Given this list of marker genes Ndufs5, Pik3ca, Fabp6, Bst1, Acads, Psmb2, Cyp7a1, Kera, B3gat2 (beta-1,3-glucuronyltransferase 2), Azin1, Gsta1, Hs3st3b1, Fabp2, Cyp24a1, Cds1, Fut2, Pip4k2c, Hgd, Pfkfb1, Pfas, Ttr, Ak7, Ddhd1, Mthfs, Fahd1, Pnpla6 (NCBI Gene Id 50767), Pla2g4b, Gnb5, Ndufa10, Cox7c, Kynu, Pnpla2 (NCBI Gene Id 68551), Me2, Inpp5k, Abhd4 (abhydrolase domain containing 4), Coq9, Slc5a5, Grhpr, Cox11, Nudt16, Isca1, Akr1c20, Cyp2a12, Hmox1, Slc25a18, Cd44, Hacd2, Phka2, Mtmr3, Enpp7, Mmab, Mkln1, Hal, Timm21, Mtmr14, Mrps36, Cyp2w1, Pgls, Lpin3, B3galnt1, Far2, Dcakd, Aaas, Aoc1, Fabp3, Glyat (glycine-N-acyltransferase), Pten, Hsd17b10, Fmo3, Gpc4, Aco1, Gatm, Miga2, Coq4, Gclm, Suclg2, Lyrm4, Sphk2, Abhd10, Osbpl2, Dpyd, Slc51a, Ugt2a3, Naxd (NAD(P)HX dehydratase), Gpi1, Ppara, Srd5a3, Lrp10, Mfsd2b, Slc44a3, Pik3r3, Pnlip, Cyp3a44, Ckm, Inpp5d, Rida, Gpat2, Mapkapk2, Th, Cyp2s1, Mocs1, Tstd1, Ptpn13, Slc25a51, Pip5k1b, Abcc1, Oca2, Gstm5, Ckmt2, Pgm2l1, Cpt1a, Sucla2, Ugt1a6a, Atp5mc2, Bpgm, Cyp3a59, Pitpnm3, Atp5me, Lpgat1, Rufy1, Alas2, Ndufb2, B4galt7, Cycs, Eci2, Cox10, Slc6a12, Ugt2b35, Nme3, Hkdc1, Rbp4, Hexa, Dbh, Gchfr, Crot, Cth, Pck1, L2hgdh, B4galnt2, Car12, Gba2, Aldh1l2, Agmo, Mmaa, Psmc1, Slc25a17, Gm2a, Smim20, Nup107, Entpd2, Tpi1, Ormdl2, Ak9, Hccs, Synj1, Ndufa13, Osbp, Pycr2, Ggt1, Bhmt, Cyp3a13 (cytochrome P450, family 3, subfamily a, polypeptide 13), Tat, Aox1, Phkg1, Abcc5, Csnk2b, Gmpr2, Lrp2, Podxl2, Nadsyn1, Pik3c3, Serinc4, Pla2g6, Cyp2e1, Mthfd1l, Pgam1, B3gnt2, Slc37a4, Ggt6, Psma7, Ndufc1, Dlst, Phykpl, Hs6st3, Akr1c21 (NCBI Gene Id 77337), Cmpk1 (cytidine/uridine monophosphate kinase 1), Ddah1, Nat2, Cox4i1, Pcbd1, Cyp3a25, Bphl, Gnb2, Tbxas1, Gna15, Ahcy, Sptlc2, Sumf2, Uck2, Pla2g5, Slc25a32, Calm3, Gng5, Ubb, Chst12, Csnk2a2, Pitpnm1, Fmod, G6pdx, Ust, Idh3a, Slco1a4, Nup160, Fabp1, Rab4a, Inpp5j, Pik3r6, Pla2g2d, Sgms2, Nmrk1, Ppa2, Fut1, Il4i1, Nudt19, Pank4, Plch2, Akr1c6, Pik3c2g, Acox1, Lipi, Slc25a14, Gng7, Slc5a8, Mccc2, Nsdhl, Far1, Rrm1, Lyrm2, Idua, Ndufaf8, Srebf2, Smox, Cyp4f39, Galk1, B3galt6, Lta4h, Got1, Arsj, Tk2, Ndufc2, Stard7, Cacna1a, Pdp2, Nme2, Agmat, Sdc4, Selenoi, Rapgef3, Isca2, Bco2, Neu2, Chst9, Dmac2l, Gpd1, Psat1, Bckdk, Psmd7, Eno2, Sumf1, Gart, Oxct2a, Gldc, B4galt2, Fmo2, Adrm1, Tbl1xr1, Pgam5, Adra2a, Akr1d1, Gpat4, Acot8 (NCBI Gene Id 170789), B4galt5, Elovl6, Itpr2, Cyp4f40, Akr1b8, Mvd, Xylb, Kcns3, Entpd6, Glb1, Cygb, Dmac2, Cyp39a1, Mgll, Aldh1l1, Acsl5 (acyl-CoA synthetase long-chain family member 5), Sumo2, Pik3c2b, Fbp2, Gm10053, Nt5e, Atp5f1b, Slco2b1, Ndufa11, Fdps, Gstz1, Stard10, Osbpl7, Adcy5, Cacnb2, Plcd4, Dcn, Cspg5 (chondroitin sulfate proteoglycan 5), Lypla1, Acsl4, Entpd4b, Surf1, Acbd4 (NCBI Gene Id 70268), Cyp2c66 (cytochrome P450, family 2, subfamily c, polypeptide 66), Psmb5, Umps, Hsd3b5, Acsm1, Psma5, Hsp90ab1, Abhd14b, Ffar1, Gpc5, Sgpp2, Ndufa12, Sult2a1, Alox12b, Comt, Cyp4a31, Slc25a13, Eci1 (enoyl-Coenzyme A delta isomerase 1), Cyp2c29 (NCBI Gene Id 13095), Acsl6, Acp5, Agxt, Ctps1, Akr1a1, Ggps1, Ugt1a1, Dguok, Arf1, Psph, Nup188, Acsm2, Vac14 (NCBI Gene Id 28016), Ormdl3, Aldob, Cda, Gid8, Ldha, Ahcyl, Apoa2, Itpa, Etnppl, Lpl, Trmt112, Pik3cb, Psma4, Acsm4, Cyp4f15, Aldoa, Lyve1, Txnrd1, B3gnt3, Inpp5b, Tymp, Hk2, Gstm6 (glutathione S-transferase, mu 6), Has3, St3gal3, Psmd14, Apom, Adal, Esd, Nudt18, Hao1, Gpx1, Gng11, Gpc3, Aspa, Has1, Gstp2, Idh3g, Ndufaf3, Cox6b1, Tk1, Gnb4, Plpp2, Ttpa, Cyb5b, Mbtps1, Psmc6, Fads2, Aanat, Scp2, Ranbp9, Alox5ap, Star, Sdhb, Adcy6, Cyp4f14, Fads1, Cryl1, Cyp3a57, Ppip5k1, Acot9, Csgalnact1, Ephx2, Has2, Hpdl, Smarcd3, Hlcs, Cyp17a1, Pom121, Cidec, Acot11, Cyp4a14, Atp5mk, Acat1, Ptdss2, Mthfr, Cyp2b23, Ncoa1, Entpd3, Nr1h4, Hpgd, B4galt4, Slc25a4, Pygl, Itpka, Amdhd1 (NCBI Gene Id 71761), Cemip, St3gal2, Slc35b3, Dnph1, Acsbg2, Sgpl1, Coq2, Fig4, Tmem186 (transmembrane protein 186), Tyms, Acat2, Nqo1, Oplah, Adipor2, Carm1 (coactivator-associated arginine methyltransferase 1), Mthfsl, Pla2r1, Gpc6, Nup37, Psmc5, Ppox, Pdxk, Tyr, Acadvl, Slc27a5, Cox4i2, Nudt12, Aoc3, Acp6, Cox8c, Ugt2b37, Hadhb, Ltc4s, Psma3, Coq10b, Cox6a1, Slc23a2, Gk2, Tpr, St6galnac6, Cyp2u1, Btd, Coq6, Mgst2, Atp5pf (ATP synthase peripheral stalk subunit F6), Tpst2, Gapdh (NCBI Gene Id 407972), Miox (myo-inositol oxygenase), Ehhadh, Papss1, Arsk, Gphn, Plcb4, Slc46a1, Lss, Lrp1, Hsd11b1, Ugcg (UDP-glucose ceramide glucosyltransferase), Cd38, Hk1, Bdh2 (NCBI Gene Id 69772), Bdh1, Alas1, mt-Cytb, Pccb, Tpo, Got2, Hs3st4, Kcng2, Acss1, Sult2b1, Txn2, Cox8a, Pdzd11 (PDZ domain containing 11), Cpne7, Ncoa2, Ptges, Agpat1, Impa2, Mgst1, Phyh, Cs, Hacd4, Asrgl1, Gadl1, Sdhaf1, Aldh2, Cyp11b2, Sgpp1, Pnmt, Lum, Adh1, Cyp3a16, Sqor, Pik3c2a, Ch25h, Akr1b7, Cox19, B4galnt1, Psmb1, Plcg2, Naprt, Pdpr, Cbr3, Gpt, Stard5, Bhmt2, Hpgds, Amt, Mvk, Prkar1a, Hmmr, Pnpla5, B4galt1, Cyp21a1, Hsd3b6, Pla2g2e, Dhcr24, Rpia, Acly, Nudt11, Pcx, Gng4, Cacna1d, Mtmr9, Nup88, Cers1, Hibadh, Gnb1, Cyp2a5, Slc25a12, Arsg, Manba, Aasdhppt, Baat, Pla2g10, Pgm1, St3gal6, Pctp (phosphatidylcholine transfer protein), Gsta5, Tm7sf2, Aldh3a2 (aldehyde dehydrogenase family 3, subfamily A2), B3galt4, Plekha2, Aprt, Pla2g12a, Rae1, Decr1, Sqle, Chkb, Ces1d, Aldh1a1, Ndufb4, Coq7, Itpr1, Stard3, Pfkl, Plekha1, Acacb, Echs1, Cmc1, Uxs1, Tph2, Adipoq, Bco1, Atp5f1c, Slc25a19, Qdpr, Ucp2, Vdr, Glud1, Lyrm7, Iyd, Slc22a5, Cidea, Uqcrb, Hdac3, Upb1, Ugt3a2, Xylt1, Gusb, Agk, Nudt4, Mthfd1, Pm20d1 (peptidase M20 domain containing 1), Ndufaf7, Tkfc, Mmachc, Cox6a2, Tdo2, Pla2g15, Hoga1, Tmem86b, Mpst, Smpd2, Sult1c2, Glb1l2, Ces2b, Dpys, Psmd8, Cox5a, Lhb, Apob, Srm, Aldh4a1, Hmgcl (3-hydroxy-3-methylglutaryl-Coenzyme A lyase), Fah, Cyc1, Elovl3, Inpp5a (NCBI Gene Id 212111), Pla2g1b, Fabp4, Plcd3, Car13, Mfsd2a, Nup58, Mgst3, Tnfaip8l2, Man2b2, Coq5, Sdc2, Glrx5, Psmd12, Agpat2, Ldhal6b, Galt, Nudt3, Ndufa5, Plaat5, Itpk1, Ctsa, Cacnb3, Ogn, Ndufs8, Hyal2, Acot3, Chst5, Aldh3a1, Sult1b1, Adsl, Gba1, Cers6, Iscu, Gpx2, Sdc3, Tkt, Chac1, Uqcrc1, Ndufs1, Psma6, Aldh1b1, Hsd17b7, Nudt1, Serinc1, Ugt2b34, Cyp26c1, Dld, Acadsb, Degs1, Cyp3a41b, Lpcat2, Arnt, Otc, Ncor2, Ndufs4, Entpd5, Nup35, Inpp1, Bmx, Man2b1, Vkorc1l1, Ggt5, Srd5a2, Fabp9, Ndufs3, Carns1, Hs3st2, Sdc1, Car7, Neu4, Pgm2, Elovl5, Ndufa3, Hexb, Upp2, Shmt1, Pdk3, Sptssa, Samd8, Pemt (NCBI Gene Id 18618), Tnfaip8, Kyat1, Ptgds, Acer2 (NCBI Gene Id 73682), Sds, Dbi, Gmpr, Suox, Omd, Thrsp (thyroid hormone responsive), Prodh2, Gstm4, Etfa, Ubc, Slc25a11, Plpp6, Bckdhb, Synj2, Cyp4b1, Ethe1, Uqcrq, Mat2a (methionine adenosyltransferase 2A), Osbpl9, St6galnac5, Enpp1 (ectonucleotide pyrophosphatase/phosphodiesterase 1), Dut, Plbd1, Faah, Ubiad1, B3galt1, Gnaq, Trap1, Nnmt (nicotinamide N-methyltransferase), Chpf2, mt-Nd3, Hacd1, Inpp5f, Hsd3b7, Entpd8, Gpat3, Man2c1, Gid4, Ndufaf6, Pank3, Mtmr7, Nmnat1, Atic, Hs6st2, Ddhd2, Car14, G6pc3, Sin3b, Gnpda1, Atp5mc3, Entpd4, Nubpl, Adk, Acot4, Seh1l, Ids, Aadat, Uros, Pnpo, Pdha2, Hadha, Sat1, Rab5if, Nup98, Nat3, Dio1, Dao, Dhcr7, Plb1, Etfb, Sptlc1, Ppt1, Plcb2, Elovl1, Slc7a5, Pdp1, Kdsr, Pik3r5, Pycr1, Hadh, Tbl1x, Agpat5, Ndst1, Bcan, Hscb, Pon3, St3gal4, Kcnc2, Bhmt1b, Tmem177, Ndufa6, Gsta2, Cpne6 (NCBI Gene Id 12891), Pla2g2a, Acad10, Adra2c, Ugt2a2, Gckr (NCBI Gene Id 231103), Higd1a, Bbox1, Ugt2b36, Cox14, Ephx1, Alad, Lpcat1, Cox18, Pgk2, Glyatl3, Neu3, Qprt, Acad11, Ddc, Cyb5a, Mdh1, Chst3, Mri1, Asmt, Ugt1a5, Txn1, Chst7, Hacl1, Aldh3b1, Akr1b10, Rap1a, Psma1, Csgalnact2, Rmnd5b, Lalba, Dctd, Hdc, Hk3, Enpp6, Nudt13, Pdss1, Mtarc2, Ttc19, Apoa4, Cyp4f18, Duox2, Bckdha, Duox1, Pik3cd, Chst13, Tnfaip8l1, Hsd17b1, Uba52rt, G6pc2, Aadac, Ak8, Sdhd, Dpep2, Phkb, Chsy1, N6amt1, Slc51b, Rbks, Ip6k2, Aspg, Rab14, Impa1, Pdha1, Pi4ka, Gng10, Psma2, Ak2, Ak4, Cyp4a12a, Oxct2b, Lhpp, Ido2 (NCBI Gene Id 209176), Naglu, As3mt, Aldh18a1, Dgat2, Pon2, Slc37a2, Slc44a2, Abcd1, Pdk1, Fmo1, Ndufaf2, Cds2, Prkaca, Slc37a1, Hmgcr, Slc36a4, Gykl1, Pld4, Idi2l (NCBI Gene Id 100039655), Lpcat3, Car3, Ckb, Chp1, Gale, Taldo1, Ndufa2, Ppip5k2, Kcnb1, Ahr, Mocos, Asns, Psmd3, Apoa1, Ndufb6, Srd5a1, Enoph1, Sirt4, Slc22a13, Pdhb, Gstk1, Slc25a10, Slc2a1, Ube2i, Ppcdc, Cndp2 (CNDP dipeptidase 2), Cacna2d2, Gstt1, Itpkb, B4gat1, Glo1, Chst14, Chdh, Lrat, Nadk, Abcc8 (ATP-binding cassette, sub-family C member 8), Rfk, Cbr4, Chac2, Mtap (methylthioadenosine phosphorylase), Acaa1b, Cox6b2, Cyp11a1, Gpc1, Pank2, Akr1e1, Hsd17b8, Gstm7, Plcd1, Agpat3, Vnn1, Pi4k2b (NCBI Gene Id 74082), Cyp51, Fdx2, Crat, Tshb, Etfdh, Cyp46a1, Higd1c, Cpt1b, Tecrl, Akr1b1, Hyal1, Dnm2 (dynamin 2), Nup205, Impdh2, Blvra, Odc1, Mtrr, Gch1, Minpp1, Hao2, Chst11, Agpat4, Plpp1, Gmps, Osbpl6, Slc25a15, Pikfyve, Rxra, Shmt2, Uqcrfs1, Hmgcs2, Pcyt2, Sec13, Plcz1, Entpd1, Asah2, Mccc1, Acot5, Etnk2, Ucp3, Nt5c1a, Gnpda2, Ggct, Mtr, Tcn2, Gck, Scap, Sgms1, Plch1, Sbf1, Acbd5, Slc25a42, Rmnd5a, Ptdss1, Paics, mt-Nd4, Gsta13, Isyna1, Ppard, Haao, Ampd1, Gys1, Ndufb3, Nt5c3, Mtmr1 (NCBI Gene Id 53332, myotubularin related protein 1), Neu1, Hsd3b1, Pitpnb, Ndufa1, Slc25a2, Decr2, mt-Nd5, Rbp2, Dhodh, Fech, Serinc2, Sphk1, Abcc3, Psmb3, Plekha3, Chka, Acaca, Cdipt, Slc23a1, Hs6st1, Nup133, Srr, Slc9a1, Pitpnm2, Ip6k3, Adipor1, Gsto1, Plekha5, Ndufb1, Idh3b, Cpne3 (copine III), Pts, Liph, Hsd3b3, Zdhhc21, Alox8, Acbd7, mt-Nd6, Cyp4a29, Ugt1a7c, Adpgk, Ndufv2, Tph1, Ggt7, Itpr3, Slc35b2, Ugt2b1, Nup85, Abhd3 (abhydrolase domain containing 3), Sdhaf2, Arg2, Ak1, Atp5f1d, Gaa, Coa3 (cytochrome C oxidase assembly factor 3), B3gat1, Gns, Ptgs1 (prostaglandin-endoperoxide synthase 1), Galns (galactosamine (N-acetyl)-6-sulfatase), Cox17, Apoc2l, Pgam2, Sdha, Hacd3, Car4, Dmgdh, Cox7a1, Asah1, A4galt, Fut7, Sult1a1, Lbr, Ndst3, Psmc2, Tmem126b, Tspo, Sacm1l, Sdhaf3, Ippk, B3gnt4, Adprm, Gls, mt-Co2, Sco2, Mecr, Acss3, Clps, Chd9, Slc44a4, Acsl3, Apoc2, Adh4, Ndufb7, Pla2g4c, Nudt5, Cmbl (NCBI Gene Id 69574), Coq8a (NCBI Gene Id 98364), Oxct1, Arg1, Acox3, Calm1 (calmodulin 1), Cd320, Nags, Scd2, B3gat3, Hspa9, Pias4, Fabp7, Pi4kb, Cyp27a1, Mboat7, Galc, Sms, Dbt, Nmnat3, Fitm1, Impdh1, Tafazzin, Slc3a2 (solute carrier family 3 (activators of dibasic and neutral amino acid transport), member 2), Alpi, B3gnt7, Sdsl, Gstm1, Idh1 (isocitrate dehydrogenase 1 (NADP+), soluble), Ugt2b38, Nnt, Atp5f1e, Gamt, Mogat1, Sgsh, Gla, Cpt2, Hsd17b2, Crls1, Abcc2, Nt5c2, Slc19a2, Cga, Aco2, Amacr, Fasn, Acsbg1, Urod, Me1, Adh7, Ldhc, Tnfaip8l3, Mogat2 (monoacylglycerol O-acyltransferase 2), Osbpl10, Prkar1b, Gapdhs, Stard3nl, Gnb3 (guanine nucleotide binding protein (G protein), beta 3), Naalad2, Slc44a1, Helz2, Ndufa8, Akt1, Pla2g4d, Nup50, Dcxr, Glrx, Inpp4b, Nup210, Ugt1a2, Idi1, Acot2, Cox5b, Pip4k2a, Nek1, Ass1, Phka1, Nudt10, Serinc3, Plcb1, Dpep1, Hsd17b11, Fxn, Gal3st1, Ido1, Pi4k2a, Pnpla3, Ip6k1, Pnp, Wdr26, Hsd17b12, Bcat2, Psmd2 (NCBI Gene Id 77434), Stard4, Slc6a11, Car1, Ecsit, Pmvk, Etnk1, Serinc5, Slc25a20, Dsel, Ndufb8, Chst15, Gcg, Azin2, mt-Atp6, Acsl1, Nos3, Pip5k1c, Plcb3, Slc2a2, Cox20, Khk, Agxt2, Acsf3, Cpne1, Pfkm, Gk, Rps27a, Plaat3, Osbpl8, D2hgdh, Cyp4a10, Hpd, Idi2, Oat, Ndufv3, Ugt1a8, Psmb6, Slc10a2, Ndufa9, Cox7a2l, Slc25a27, Cyp4v3, Nup54, Them5, Aldh6a1, Nt5c, Sco1, Gnas, Kcnj11, Pfkfb3, Abcd4, Cyp4a32, Acsm5, Cyp8b1, Miga1, Aldh3b2, Osbpl3, Nfs1, Psmc4, Rbp1, Nme1, Ndufs7, Adi1, Phkg2, Sdhc, Ivd, Ugt2b5, Nme4, Naxe, Psap, Rimklb, Arv1, Tecr (NCBI Gene Id 69708), Acaa2, Pdhx, Thtpa, Gpihbp1, Itpkc, Hmgcs1, Car2, Cox15, Agl, Hibch, Slc52a3, Hykk, Ctps2 (NCBI Gene Id 55936), Upp1 (uridine phosphorylase 1), Pgd, Xylt2 (NCBI Gene Id 217119), Elovl2, Dera, Ndufa4 (NCBI Gene Id 17992), Alox5, Them4, Cd36, Ugt1a9, Slc45a2, Serpina6, Nup155, Hs3st6, Arnt2, Idh2, Slc25a22, Prodh, Pdk2 (pyruvate dehydrogenase kinase, isoenzyme 2), Papss2, Pnp2, Adss2, Inpp4a, Ldhb, Slc6a7, Plekha8, Gpd2, Gcdh, Ocrl, Mtarc1 (NCBI Gene Id 66112), Abo, St3gal5, Cyp2f2, Higd2a, Alox12, Plcg1, Hsd3b4, Cyp3a11, Prps2, Asl, Ptges3, Slc26a2, Nosip, Rrm2, Cbr1, Plekha6, Pomc, Ndufaf5, Adh5, Chsy3, Inppl1, Cyp19a1 (cytochrome P450, family 19, subfamily a, polypeptide 1), Mthfd2, Vcan, Pla1a (NCBI Gene Id 85031), Dtymk, Armc8, mt-Nd2, Folr2, Ugt3a1, Pudp, Ado, Ces3a, Mocs3, Sptlc3 (NCBI Gene Id 228677), Ces3b, Ugt2a1, St8sia5 (ST8 alpha-N-acetyl-neuraminide alpha-2,8-sialyltransferase 5), B4galt3, Ada, Acsf2, Ext1, Arf3 (ADP-ribosylation factor 3), Cps1, Fitm2, Ampd2, Fut4, Aip (aryl-hydrocarbon receptor-interacting protein), Ppp1r3c, Tpst1, Uroc1, Uqcrh, Prkaa2, G6pc1, Dlat, Pon1, Psmd13, Ftcd, Gnai2, Pfkfb2, Ldlrap1, Ndufb10, Cyp2a4, Cyp2a22, Ndufs2, Lclat1, Cers3, Hsd3b2, Gnai1, Sc5d, Pdss2, Hs3st5, Gng13, Coq10a, Smpd4, Slc35d1, Prkacb, Hsd3b8, Gngt2, Dgat2l6, Cyp27b1, Aldh9a1, Cers2, Phgdh, Cerk, Cyp1b1, Ugdh, Coasy, Pck2 (phosphoenolpyruvate carboxykinase 2 (mitochondrial)), Agrn, Gpt2, Timmdc1, Ugp2, Ndst2, Pik3r1, Mboat1, Slc10a1, Ampd3, Gclc, Nat1, Rpe, Atp5mj, Mdh2, Atp5pd, Xdh, Carnmt1, Amd1, Hgsnat, Acot1, B3galt5, Car9, Samhd1, Mcat, Slc52a2 (solute carrier protein 52, member 2), Coq3, Chat, Gsr, Cblif (cobalamin binding intrinsic factor), Ranbp2, Pik3r4, Mcee, Fabp12, Fdx1, Fpgs, Cyp11b1, Mat2b, Acy3, Pik3r2, Gde1, Ndst4, Prkag2, Mmut, B4galt6, Ebp, Plaat1, Pfkfb4, Slc44a5, Ppcs, Arsi, Pla2g2f, Cyp1a2, Nostrin, Awat1, Glyctk (NCBI Gene Id 235582), mt-Co3, Gyg1 (NCBI Gene Id 99787), Dct, Pld6, Nudt9, Fdft1, mt-Co1, Ppa1, Acer3, Calm2 (calmodulin 2), Lmbrd1, Cox16, Ndufb9, Ext2, Inpp5e, Oaz2, Gng8 (NCBI Gene Id 14709), Gngt1, Alox15, Hpse2, Nt5m, Nt5c1b, Ak6, Prps1l3, Bpnt2, Hs2st1, Uqcr10, Tpk1, Gcsh, Me3, Psmb4, Gng3, Cyp4a30b, Nup93, Pla2g4a, Ddo, Pla2g3, Tyrp1, Hagh, Gna14, Vdac1, Vkorc1, Acad8, Cyp3a41a, Ndufv1, Flvcr1, Nup153, Ormdl1, Aldh7a1, Elovl7, Chpf, Mtm1, Glul, Sult1e1, Ak5, Gc, Pgp, Pip5k1a, Atp5po (ATP synthase peripheral stalk subunit OSCP), Gsta3, Slc25a21, Sts, Nup214, Mlycd, Cdo1, Pik3cg, Glb1l, Entpd7, Paox, Smpd3, Fbp1, Pnpla8, Acot13 (NCBI Gene Id 66834), Hyal3, Ndc1 (NCBI Gene Id 72787), Slc19a3, Rdh11, Ucp1, Pla2g4e, Ahrr, Slc26a1, Scly, Aldoc, Sephs2, Dhrs7b, Prps1l1, Fa2h, Blvrb, Cox6c, Cbs, Prkab2, Cox7b, B3galt2, Mmadhc, Nampt, Slc25a16 (solute carrier family 25 (mitochondrial carrier, Graves disease autoantigen), member 16), Gss, Slc2a3, Acy1, Pla2g4f, Flad1, Ndufs6, Spns2, Fh1, St3gal1, Fdxr, Cyp26b1, Mthfd2l (methylenetetrahydrofolate dehydrogenase (NADP+ dependent) 2-like), Cacna1e, Gpc2, Nup43, Chst2, Ndufab1, Acox2, Gna11, Tgs1, Med1, Dio3, Degs2, Chst1, Aloxe3, Nqo2, Uqcrc2 (NCBI Gene Id 67003), Cyp2c65, Hs3st3a1, Acot12, Rnls, Oaz1, Mtmr6, Plce1 (NCBI Gene Id 74055), Psmd6, Prps1, Morc2a, Ckmt1, Auh, Pip4k2b, Hprt1, Sdhaf4, Bgn, Maob, Gstm2, Psmc3 (proteasome (prosome, macropain) 26S subunit, ATPase 3), Gsto2, Aass, Alb, Galm, Psmd11, Awat2, Glb1l3, Dhtkd1, Mat1a, Ppm1k, Hsd17b14, Apoe (apolipoprotein E), Plekha4, Mtmr2, Prelp, Acad9, Dmac1, Cyb5r3, Psmb7, Dck, Gnmt, Osbpl1a, Lrp12, Marcks, Ipmk, Acadl, Gpx4, Tpmt, Folh1, Hilpda, Glp1r, Hsp90aa1, Akr7a5, mt-Atp8, Uckl1, Pyurf, Coa5 (NCBI Gene Id 76178), Dse, Lrp8, Osbpl5, Aacs, Shpk, Hsd3b9, Bpnt1, Gstt2, Guk1, Pkm, Pygm, Srebf1, Psmd1, Nudt15, Sult2a2, Ppt2, Eno4, Coq8b, Hmox2, Nmral1, Nadk2, Mboat2, Lpin2, Oaz3, Cers5, Sin3a, Gstm3, Car5b, Cyp2d22, Gda, Msmo1, Rrm2b (ribonucleotide reductase M2 B (TP53 inducible)), Maoa, Ptges2, Abcb11, Pfkp, Plpp3, Mbtps2, Ugt8a, Cyp1a1, Atp5pb, Hsd17b4, Nat8l, Kmo, Cers4 (ceramide synthase 4), Cpox, Nup42, Cox7a2, Slco1b2, Pdk4, Ndufb11, Csnk2a1, Cacna1c, Crym, Sptssb, Maea, Cav1, Adss1, Cyp4a12b, Ptgs2, Rapgef4, Gng2, Cyp7b1, Dgat1 (NCBI Gene Id 96948), Gls2, Acan, Cyp2r1, Stard6, Lpcat4, mt-Nd1, Atp5f1a, Chpt1, Rab5a, M6pr, Pcyt1a, Cad, Tspoap1, Gng12, Acadm, Cept1, Phospho1, Stab2, Hsd11b2, Nmrk2, Adhfe1, Acoxl, Gstp1, Ndufaf1, Slc35d2, Nmnat2, Slc19a1, Nup62, Gcgr, Acss2, Gbe1, Gpd1l, Cspg4, Arsa, Sardh, Pycr3, Ran, Atp5mg, Acbd6, Pank1, Pld2 (NCBI Gene Id 18806), Pah, Cyp26a1, Car5a, Pipox, Eno3, Ndufb5, Pecr, Dhfr, Ndufaf4, Ogdh, Car6, Slc5a6, Spr, Acer1, Tst, Slc27a2, Fut9, Hsd17b13, Tpte, Pcyt1b, Smpd1, Sult4a1, Gnpat, Hmgcll1, Rimkla, Hmbs, Gpam, B3gnt5, Slc6a8, Atp5mc1, Arsb, Pip4p1, Sirt3, Kpnb1, Ndufa7, Uck1, Pcca, Suclg1, Hpse, Aoc2, Hs3st1, Mtmr4, Cyp2j6, Hsd17b3, Pgk1, Ptgis, Bcat1, Atp5mf, Ppat, Mtmr12, Sult6b1, Mid1ip1, Fabp5, Acot7, Uba52, Sord, here is a description of the gene set: studied in species Mus musculus Metabolism Mouse Gene Set: REACTOME_METABOLISM